The following is a description of a gene set: The chemical reactions and pathways by which a cell derives energy from stored compounds such as fats or glycogen. Mouse Gene Set: GOBP_ENERGY_RESERVE_METABOLIC_PROCESS species: Mus musculus, and this is the list of marker genes: Phlda2, Tcf7l2, Per2, Pygb, Adgrf5, Ins2, Comt, Ppp1r3g, Gys1, Mup3, Prkag2, Wdr45, Khk, Pgm2, Ppp1r3f, Mc4r, Gsk3b, Ptges3, Atg12, Gbe1, Ppp1r3e, Col6a1, Stbd1, Wipi2, Epm2aip1, Akt2, Lepr, Epm2a, Pfkm, Ppp1cc, Atg2b, Adrb1, Gys2, Pygl, Grb10, Gnas, Hmgb1, Mrap2, Prlh, Nr1d1, Acadm, Mup5, Igf2, G6pc1, Ugp2, Gaa, Rubcnl, Mtor, Irs2, Stk40, Irs1, Gsk3a, Pygm, 1810024B03Rik (NCBI Gene Id 78310), Wipi1, Ppp1r3c, Enpp1, Ppp1cb, Pcdh12, Phkg1, Phka2, Dyrk2, Pth, Selenon, Blvra, Pgm1, Ppp1r3a, S100b, Rb1cc1, Gyg1, Adcy10, Nhlrc1, Igf1, Atg2a, Adra1b, Inpp5k, Mup11, Mup4, Eva1a, Atg3, Phka1, Ppp1r1a, Gck, Lep (leptin), Slc37a4, Ppp1r2, C1qtnf2, Pomc, Phkb, Il6st, Gnmt, Prkag3, Esrrb, Gabarapl1, Agl, Ppp1ca, Wdr45b (WD repeat domain 45B), Mt3, Pgf, Akt1, Gcgr, Kl, Mup2, Ppp1r3d (protein phosphatase 1, regulatory subunit 3D, NCBI Gene Id 70414), Insr, Phkg2, Ppp1r3b, Mup1, Ins1 (NCBI Gene Id 16333), Sorbs1 (NCBI Gene Id 75688), Pask, Gfpt1, Adgrf1